Given this list of marker genes RPS5, ADIRF, JUN (Jun proto-oncogene, AP-1 transcription factor subunit), RPL23A (NCBI Gene Id 6147), TM9SF3, RPL31, RPL35A, RPS18 (NCBI Gene Id 6222), RPL13 (NCBI Gene Id 6137), DGKD, IER3, EEF1A1, PPP1R1B, RPL4, RPS9 (ribosomal protein S9), RPL14, RPL27A, LYZ, PIGR, EPS8L3, RPL23, RPS16, RPL36, CXCL17, RPLP2, RPL26, RPS27A, EEF1B2, RPL7, PTPRF, RPL27, RPL32 (NCBI Gene Id 6161), NPM1, ATF3, IMPA2 (NCBI Gene Id 3613), RPL37, RPL12, RPS20, SDC4, SOCS3, RPL29 (NCBI Gene Id 6159), SERBP1, RPL30, RPS2, RPS14, SULT1C2, TUBA1B, RPS4X, RPL3, RPL8, RPL39, IMPDH2, EEF2, RPS24 (ribosomal protein S24), GOLM1, GSTP1, RPL22, GPX2, RPL9, TACSTD2, TSPAN8, CLU, RPS29 (NCBI Gene Id 6235), SAT1, RPS19, RPS27, MARCKSL1, GATM, RPL18, RPS10, RPS13, SNHG29, RPL10A, ELF3, MLPH, ABCC3, RPS23, ADH1C, RPL35, ALDH3A1, PPIA, RPS21, ADD3, RPL15, RPL17, EEF1G, RPL7A, RPL41, PABPC1, RPS15 (ribosomal protein S15), EPCAM, RPS3A, RPL37A, HSP90AB1, RPL28, SPINT2, RPS6, RPS12, RPS8, CALM2, RPS15A, KCNE3, RPS3, RPL11, CTSE, RPL5, RPL34, RACK1, RPLP0, TMPRSS2, RPS28, RPL13A, RPL18A, FOS, RPL19, PTMA, EGR1, LGALS3, FOSB (NCBI Gene Id 2354), HNRNPA1 (NCBI Gene Id 780920), SOX9, here is a description of the gene set: species: Homo sapiens Human Gene Set: BUSSLINGER_GASTRIC_PPP1R1B_POSITIVE_CELLS from publication Busslinger GA, Weusten BLA, Bogte A, Begthel H, Brosens LAA, Clevers H (PMID 33691112)